Given this list of marker genes Amigo1, Ephb2, Casp6, Ncam2 (neural cell adhesion molecule 2), L1cam, Sema5a, Ncam1, Ephb3, Fezf2, Cdk5r1, Rtn4 (reticulon 4), Megf8, Sema3a, Tnfrsf21, Cntn2, Nrp1, Epha4, Casp3, Crtac1, Celsr3, Ndn, Cnr1, Epha3, Arhgap35, Wnt5a (wingless-type MMTV integration site family, member 5A), Ptprz1, here is a description of the gene set: The collection of axons into a bundle of rods, known as a fascicle. Mouse Gene Set: GOBP_AXONAL_FASCICULATION species: Mus musculus